Given this list of marker genes AP3B1 (adaptor related protein complex 3 subunit beta 1), CSNK1G3, USP10, ANKRD33B, IL4 (NCBI Gene Id 3565), FBXO30, LRWD1, BORA, GRHL1, WAPL, RPP14, ZNF541, MRPL40, DEPDC5, NMRK1, ZNF446, ZCRB1, NDUFAF1, POLR1E, PON3, POLR3H (RNA polymerase III subunit H), HIBCH, RBM28, AKIP1, SNX27, PAPLN, CPPED1, SLC6A9, FAM220A, SLF1, TUFT1, E2F6, CEP162, PDCD1LG2, TEX10, NAA16, ZEB2, SARNP, QSOX2, RHAG, MAD2L2, CPSF2, MRPL35, LYPLA1, TXN2, TDRKH, EXOC4, ASCC2, GKAP1, REEP5, FARP2, KMT5A, FZR1, NDE1, CFAP299, ALG6 (ALG6 alpha-1,3-glucosyltransferase), NAB1, NAA35, PPP1R16B, MTMR6, FBLN5, MANSC1, GPR89B, MRPS31, DDX21, ALOX5, CRYBG3, PRKRA, HHAT, GPN1, HACE1, PWP2, TYMS, MBD5, SLAMF7, WDR31, TRIM45, ST6GALNAC1, DHRS7B, CCNE1, KRTCAP2, COX6A1 (cytochrome c oxidase subunit 6A1), TNFSF9, ARHGAP5, CENPU, DEDD, SYNCRIP, DCUN1D3, TCERG1 (NCBI Gene Id 10915), SMCO4, LTBP3, KCNF1, ABTB2, STOML2, PER1, UCK2, BCORL1, KCTD11, SLC6A6, ZNF518B (NCBI Gene Id 85460), PRR13, ALPK2, POLR1C, PTGER3, EIF2B5, ANAPC10, SLC7A6, RSPRY1, PLPP2, GPNMB, MTFR1, THG1L, UBE2E3, YES1, TNFSF14, INTS11, R3HDM1, OTUB2, CYB561, PRMT2, EIF2D, NEMP1, FANCL, DCLRE1A, ELOF1, CDHR4, PGP, FGFBP1, PREPL, ALKBH2, NR2F6, MLF1, RPA3, TRAF4, ABHD18, PEX13, PRDM2, POGLUT2 (NCBI Gene Id 79070), FBXO45 (NCBI Gene Id 414772), FBXL20 (F-box and leucine rich repeat protein 20), DNAJB4, DOCK7, RNASEH2B, ITFG2, CHCHD1, PLA1A, EXO1, TMEM107, UBL3, SEPHS2, MGAT4B, UBE2K, NKAIN4, CEP290, KDELR2, DCAF17, SLC16A3, VSTM5, NAT9, SURF4, ARL1, IFT122, DOT1L, AATK, TMEM40, CCDC137, METRNL, GYG1, NTMT2, C6orf141, AKR1B15, GDPD5, KLF10, PAIP1, DGLUCY, DOC2A, SDHC, MCTP1, EFCAB2, WDR43, LCLAT1, L2HGDH, CCDC18, SLC25A30, GNG2, CMC2, ZNF266, UEVLD, MSC, SLC30A3, TOPBP1, SAE1, AUNIP, MTO1, RPGR, AGPS, INTS3, DCTN6, SNX18, TFAP2E, here is a description of the gene set: Transcription factors that regulate quiescence, proliferation, and homing of lymphocytes are critical for effective immune system function. In the present study, we demonstrated that the transcription factor ELF4 directly activates the tumor suppressor KLF4 downstream of T cell receptor (TCR) signaling to induce cell cycle arrest in naive CD8+ T cells. Elf4- and Klf4-deficient mice accumulated CD8+CD44hi T cells during steady-state conditions and generated more memory T cells after immunization. The homeostatic expansion of CD8+CD44hi T cells in Elf4-null mice resulted in a redistribution of cells to non-lymphoid tissue due to reduced expression of the transcription factor KLF2, and the surface proteins CCR7 and CD62L. This work describes the combinatorial role of lymphocyte-intrinsic factors in the control of T cell homeostasis, activation and homing. Genes down-regulated in comparison of naive CD8 T cells from ELF4 defficient mice versus activated CD8 T cells from ELF4 defficient animals. studied in species Homo sapiens Human Gene Set: GSE15324_NAIVE_VS_ACTIVATED_ELF4_KO_CD8_TCELL_DN from publication Yamada T, Park CS, Mamonkin M, Lacorazza HD (PMID 19412182)